The following is a description of a gene set: species: Homo sapiens Abacavir ADME Human Gene Set: REACTOME_ABACAVIR_ADME, and this is the list of marker genes: ABCG2, SLC22A3, ABCB1, SLC22A1, NT5C2, MAPDA, ADH1A, SLC22A2, PCK1 (phosphoenolpyruvate carboxykinase 1)